Given this list of marker genes MAPK3, PITX2, FOXC2, EGFR, MAP3K1, JUN, BMP4, NOTCH1, INHBB (NCBI Gene Id 3625), MAPK9, SMAD1, FOXC1, SMAD4, DKK2, TGFA, FGF10, SMAD5, SFRP1, SHH, FGFR2, here is a description of the gene set: BMP signaling in eyelid development Human Gene Set: WP_BMP_SIGNALING_IN_EYELID_DEVELOPMENT studied in species Homo sapiens